The following is a description of a gene set: Human Gene Set: GOMF_CYTIDYLYLTRANSFERASE_ACTIVITY Catalysis of the transfer of a cytidylyl group to an acceptor. studied in species Homo sapiens, and this is the list of marker genes: PCYT1A, PCYT2, PCYT1B, CRPPA, CDS1, CMAS, TAMM41, TRNT1, CDS2